Given this list of marker genes Prdx6, Selenof, Prxl2b, Prdx2, Prdx3, Prdx1, Park7, Prdx5, Prdx4 (peroxiredoxin 4), here is a description of the gene set: studied in species Mus musculus Mouse Gene Set: GOMF_PEROXIREDOXIN_ACTIVITY Catalysis of the reaction:-dithol + ROOH =-disulfide + H2O + ROH.